Given this list of marker genes KDM5A, DHX30, LAMP5, SPATA8, LRRC37A6P, LAMC2, NRG2, CELF2, NR3C2 (NCBI Gene Id 4306), ZNF644, MAP1A, CEP170, TBX15, COL12A1, UBE2D1, BTBD1, BTF3L4, CAMTA1, ALG8, BICD1, CHST2, ESRRG, MSI2, TOR2A, N4BP1, NR4A3, PTPN2, EPB41L1, ZNF280C, CHODL, TMEM200B, NRCAM, CD34, AMIGO1, LHX8, PITPNA, RBCK1, PTPRF, NETO1, STX5, SMAD4, RAB24, KCNJ2, PDLIM7, MAP2K4, here is a description of the gene set: Human Gene Set: GCAAGAC_MIR431 studied in species Homo sapiens Genes having at least one occurence of the motif GCAAGAC in their 3' untranslated region. The motif represents putative target (that is, seed match) of human mature miRNA hsa-miR-431 (v7.1 miRBase).